The following is a description of a gene set: studied in species Homo sapiens Human cytomegalovirus induces a pro-inflammatory monocyte following infection and we have evidence that NF-κB and phosphatidylinositol 3-kinase are key mediators in this early activation. To begin to address how these signalling pathways are responsible for the rapid activation of infected monocytes, we examined the role these pathways played in the transcriptome of infected monocytes. Global transcriptional profiling using cDNA microarrays revealed a significant number of genes, including inflammatory genes, were regulated in a NF-κB- and/or PI(3)K-dependent manner, identifying these pathways as key cellular control points in the conversion of monocytes to an activated pro-inflammatory state following HCMV infection. from publication Chan G, Bivins-Smith ER, Smith MS, Yurochko AD (PMID 18003728) Human Gene Set: GSE9601_UNTREATED_VS_PI3K_INHIBITOR_TREATED_HCMV_INF_MONOCYTE_UP Genes up-regulated in monocytes after HCMV infection: untreated versus Ly294002., and this is the list of marker genes: GIMAP7, CXXC1, MED15, OS9, PSMC4, WBP1, MED8, CARMIL2, FLII, PSMB4, GIT2, PAFAH1B3, CAPG, CDC42SE1, SSRP1, RGS16, MIIP, TRAF1, RAB4B, RBCK1, ARHGAP27, PRRC2B, SIPA1, SF3A3, RPL18, RCC2, UCP3, TMA7, MCM3, EHMT2, TMCO4, SCPEP1, CHMP4B, CCDC97, GTF2F1, CBLB (Cbl proto-oncogene B), TMEM158, CSRP1, ELOB, CORO1A, ANXA6, FILIP1, ACTL7B (actin like 7B), H2BC3, TACC1, MAD1L1, MYO1F, ZFP1, NOSIP, RGS14, HMGN2, CIT, MAP4K2 (NCBI Gene Id 5871), H4C6, EZR, SASH3 (NCBI Gene Id 93952), NCAPD3, NFKBIE, MEA1, IRF9, MXD1, RPL41, POLR2L, H1-1, MYH9 (myosin heavy chain 9), CYBA, DDX54, LSM3, TPX2, TUBGCP2, RPL28, H4C16, SNX15, ARL6IP4, RPS26, PHYH, MBD3, H2AC25, RPL37A, RELB, CSF1, DCTN4, H4C4, RAB1B, ARHGEF1, PSMB10, CCDC12, CTBP1, FMNL1, ACSBG1, OSBPL5, TOMM5, CSNK1G2, PUF60, GBP3, SORL1, HNRNPL, H4C14, GIPC1, CDH12, GRAP, PPP1R9B, EPSTI1, NDUFS5, SAMHD1, DPY30, THAP7, USP36 (ubiquitin specific peptidase 36), SECISBP2, DPP9, ZC3H7B, DNMT1, SF3B2 (splicing factor 3b subunit 2), SRRT, DDA1, FRMD8, SHKBP1, DSN1, BSG, RFWD3, FKBP8, SIRT7 (NCBI Gene Id 51547), IRF4, PREX1, H1-5, TSSC4, SPRR1B, ELAVL4, BIRC5, SRGAP3, LRRC8A, ARHGDIA, SDF4, ANKRD11, MYO18A, EXOC7, PDGFB, EHD4, ARHGAP45, GRK2, TLN1 (NCBI Gene Id 7094), NDUFA8, NDUFB11, E2F7, H2AZ2, PRKCQ, KIF2C, IRF1, TNIP1, BAIAP3, CKAP2, SERF2, PIM1, MAP2K2, RPL38, CDCA8, B4GALT7, DDX41, BRCA1, GBP4, LCP1, IRF3, LMNB1, YBX1, RNASEH2C, RPS29, PTPRS, JAML, BDH1 (NCBI Gene Id 622), PDE4DIP, IGF2R, NDUFS8, TFEB, CRACR2A, PYCARD, CFDP1 (craniofacial development protein 1)